Given this list of marker genes ILDR2, HLA-DMB, TIGIT, BCL6, CD69, CBFB (NCBI Gene Id 9163), PNP, ZP3, SMARCD2, PLA2G2F, HLA-DMA, WNK1, SOX13, DPP4, CLECL1P, NFAT5, TRAF6, NT5E, IL12B, CLEC4G, PLA2G2A, IL1RL2, JAK2, ICOSLG, SMARCD3, IL12A, BMP7, AKT1, ITGB2, BTLA, BMP4, CYRIB, ITGAL (integrin subunit alpha L), ZC3H12A, KLF4, GCNT1, HLA-DQB1, HLA-DRA, VSIG4, VNN1, PODXL2, CARD11, IL20RB, MAP3K8, YWHAG, EP300, TMEM131L, ADD2, ICOS, THY1, HLA-DRB3, SMARCA2, EBI3, IL7R, SRC, CXCL12, TGFBR2, MIA3, CD55, IL1B, SDC4, HLA-A, HLA-E, TARM1, GNRH1 (gonadotropin releasing hormone 1), SFTPD, MTOR, NFKBIZ, SLC7A1, PLA2G5, CCL2, ITPKB, FUT4, KLRK1, HLA-DRB1, PIK3R6, JAK3, TESPA1, PBRM1, DAPL1, PCK1, IFNG, RAG2, SOX12, ELANE, NCKAP1L, CD177, LAPTM5, F11R, FUT9, LCK, LRRC32, IL7, MIR31, PRNP, CALCA, TNFSF13B, CBLB, RPS3, FOXO3, IRAK1, EFNB1, S100A8, CD160, ERBB2, IL4, MIR125A, MIRLET7E, ITCH, ADTRP, GATA3, PDPK1, ADA, CD1D, SMARCE1, ITGA5, FGL1, BMI1, NKAP, CCL19, LYN, HAVCR2, CD28, HES1, GLMN, LGALS9, MALT1, NOD2, HLA-DQB2, IGFBP2, FERMT3 (FERM domain containing kindlin 3), ARID2, IL2RG, LGALS1, CCR2, CX3CR1, SASH3, CD44, HSPD1, SLC4A2, IL15, LGALS9B, PELI1, PECAM1, ARID1B, SMARCC2, CD6, MIRLET7G, SMAD7, AP3B1, AIF1, PRKCQ, CYLD, NRARP, PPP3CA, PPARA (peroxisome proliferator activated receptor alpha), FLOT2, EGR3 (early growth response 3), SCRIB, ASCL2, DOCK8, RIPK2, SOX4, ST3GAL4, SMARCA4, SELE, SELPLG, TNF, CD47, KAT5, STAT5A, FBXO38, BRD7, MIR141, LILRB2, GPAM, CASP3, SHH, DHPS, UFL1, CD80, PTPN6, ITGA4, CD37, CCL21, PTPN11, GOLPH3, MADCAM1, DUSP22, RELA, SART1, CTLA4, CCR7, EFNB2, IFNA2, IL21, FOXJ1, MIR222, TNFSF14, YES1, XBP1, SELENOK, KITLG, OLR1, CHST4, CD27, MIR221, IL18, SMARCD1, LOXL3, ICAM1, CD81, HLA-DQA2, LEF1, CAV1, GLI3, ZP4, EFNB3, PDCD1, ACTL6A, CD274, VAV1, RC3H2, PRDX2, UMOD, ANXA1, GFUS, LILRB4, CD86, PRKCZ, PRKAA1, ZC3H8, SIRPB1 (signal regulatory protein beta 1), CD4, IL2 (NCBI Gene Id 3558), IFNL1, IRF1, KLHL22, SPN, NR5A2 (NCBI Gene Id 8768), TNFAIP8L2, ALOX5, PHF10, ZMIZ1, DNAJA3, FUT7, IL36B, VCAM1, IL4I1 (interleukin 4 induced 1), FCHO1, CD300A, NR4A3, RIPOR2, CLEC4M, IL12RB1, ARID1A, IGF2, SLC39A8, CHST2, GPNMB, EZR, HFE, MAD1L1, RASAL3, MIR30B, BCL10, ZAP70, IL2RA, TNFSF18, PIK3CD, SELP, LAX1, SOCS1, MIR92A1, ADAM8, HLA-DOA, ZBTB7B (zinc finger and BTB domain containing 7B), SMARCB1, CD3E, CEBPB, KLRC4-KLRK1, TSPAN32, S100A9, IL6ST, HAS2, TFRC, LGALS3, ACTB, KLHL25, LRG1, HLA-DQA1, ZBTB16, SYK, CD209, HHLA2, RHOH, IDO1, TMIGD2, GPR65, FYN, RAC2, SIRPA, CR1, STK10, HLA-DPB1, DUSP3, IL1A, STAT5B, CDKN2A, B2M, BRD4, ITGB1, RARA, CCL5, CERCAM (cerebral endothelial cell adhesion molecule), TNFRSF14, FOXP3, NDFIP1, HSPH1, CD5, RC3H1, IL23R, TYK2, PAG1, IGF1, TNFSF4, RUNX3, RASGRP1, CRTAM, PRKAR1A, IL10, PLA2G2D, MIR27A, EPO, ARG2 (arginase 2), ABL1, ZBTB1, ASS1, MDK, HLX, IL23A, FADD, TNFRSF21, SHB, BRD2 (bromodomain containing 2), OPA1, SEMA4D (semaphorin 4D), XCL1, SOCS6, VSIR, SKAP1, PTPN2, SLAMF1, SELL, DLG1, TNFSF9, PTPRC, RUNX1, CTSG, MSN, IL4R, TNFRSF13C, GLI2 (NCBI Gene Id 50806), SCGB1A1, VTCN1, LILRB1, LAG3 (lymphocyte activating 3), CD40LG, MIR181C, ARG1 (arginase 1), CCDC88B, ACTL6B, AP3D1, PTPN22, LEP, ROCK1, IL6, SIRPG, CCL28, ZDHHC21, WNT10B, TNIP1, MIR21, DLG5, ETS1, CD83, PYCARD, RHOA, JAM2, IHH, HLA-DPA1, DTX1, AGER, HLA-DOB, LGALS8, TNFSF11, NLRP3, ITGB7, LGALS9C, IFNB1, CD276, APOA4, HLA-G, RAG1, TGFB1, NCK1, FGL2, HLA-DRB5, TWSG1, NFKBID, CD24, HLA-DRB4, CORO1A, CSK, ADORA2A, BTN2A2, CD74, SOCS5, MIR146A, CD46, SPTA1, CCL25, BTNL2, HMGB1, EXT1, CD70, BAD, SMARCC1, DUSP10, NCK2, PDCD1LG2, ABL2, MARCHF7, PAWR, TBX21, AMBRA1, here is a description of the gene set: studied in species Homo sapiens Human Gene Set: GOBP_LEUKOCYTE_CELL_CELL_ADHESION The attachment of a leukocyte to another cell via adhesion molecules.